The following is a description of a gene set: species: Homo sapiens from publication Chen Y, Wang X (PMID 31504780) Genes predicted to be targets of miRBase v22 microRNA hsa-miR-563 in miRDB v6.0 with MirTarget v4 prediction scores > 80 (high confidence targets). Human Gene Set: MIR563, and this is the list of marker genes: DYNAP, ST8SIA3, TTC19, RARS1, NAV1, ZBBX, LINC02901, HTATIP2, NOP14, CTPS2, C2orf69, BACH1, UHRF1, PDE11A, GPC6, MYO1D, MRPS30, CRPPA, RTN1, CPN2, RNF111, WNK3 (WNK lysine deficient protein kinase 3), PBRM1, CLEC12B, ITGAV, PLEKHF2, KMT2A, MICAL2, SEL1L, CAGE1, IGLL1, ZNHIT6, NRBP2, ZNF510, COL1A2